Given this list of marker genes Tgfb2, BC037156, Twist1, Angpt1, Tgfb3, Nod2, Cuedc2, Ifnb1, Tnf (NCBI Gene Id 21926), Axl, Il10, Lilrb4a, Apoa2, Vsir, Tbx21, Lilrb4b, Epx, Atg9a, Vpreb3, Siglecg, Tmbim6, Apoa1, Il33, Jak3 (NCBI Gene Id 16453), Prg2, Hfe, Prkdc, Irak3, Hmox1, Rabgef1, Twist2, Cd96, Fcgr2b, Parp3, Foxp3, Bcl6, Smad7 (SMAD family member 7), Cd22, Tgfb1, Acp5, Bst2 (bone marrow stromal cell antigen 2), Ndfip1, Il13ra2, Slamf1, Nlrx1, Zpbp2, Arg1, here is a description of the gene set: Any process that stops, prevents, or reduces the frequency, rate, or extent of the production of molecular mediator of immune response. Mouse Gene Set: GOBP_NEGATIVE_REGULATION_OF_PRODUCTION_OF_MOLECULAR_MEDIATOR_OF_IMMUNE_RESPONSE studied in species Mus musculus